Given this list of marker genes Retreg3, Cers6, Slc34a1, Nr2f2, Dync1i2, Atf2, Ahcyl2, Stk39, Lce1h, Sirt1, Snrk, Hnrnpu, Mb21d2, Lce1f, Lce1i, Pmch, Zfp148, Cdh17, Pierce1, Cxadr, Kcnma1, Dtx3l, Trim75 (tripartite motif-containing 75), Tpbg, Ap1s2, Fam149b, Kcna2 (NCBI Gene Id 16490), Slc12a7, Irf6, Slc18a1, Rc3h1, Dnajb9, Fsd1l, Amd1, Abhd17b, Rpl37rt, Cnbp, H2az1, Metap2, Il1rn, Nap1l2, Gvin1, Ppp1r26, Cdh4, Slc25a31, Atp1b1, Megf8, Ccdc3, Khdc4, Phkb, Mapk9, Or5d38, Cbx3, Nr6a1, Rnf44 (ring finger protein 44), Amd2, Elmo1, Pot1a, Lrrn1, Cgn, Gvin2, Rbm39, Ubxn8, Rdh8, Frk, Ppp3r1 (protein phosphatase 3, regulatory subunit B, alpha isoform (calcineurin B, type I)), Ipcef1, Rnf17, Klhl9, Shisa6, Ccr7, Kif21a, Hnrnpk, Tspyl4, Smad4, Arhgap21, Nsrp1, Slain1, Rab10, Dner, Bmper, Dyrk1a, Nexmif, Stk35, Chmp1a, Tnfaip8l3, Rnf146, Zswim6, Herpud1, Gls, Pole4, Pcdh7, Nhp2, Fubp1, Ston2, Kdm2b, Wdr76, Itgb4, Gnpat, Taok1, Sec24a, Shisa9, here is a description of the gene set: Mouse Gene Set: MIR_6899_5P studied in species Mus musculus from publication Chen Y, Wang X (PMID 31504780) Genes predicted to be targets of miRBase v22 microRNA mmu_miR_6899_5p in miRDB v6.0 with MirTarget v4 prediction scores > 80 (high confidence targets).